The following is a description of a gene set: studied in species Homo sapiens The process whose specific outcome is the progression of the paraxial mesoderm over time, from its formation to the mature structure. The paraxial mesoderm is the mesoderm located bilaterally adjacent to the notochord and neural tube. Human Gene Set: GOBP_PARAXIAL_MESODERM_DEVELOPMENT, and this is the list of marker genes: WNT5A, FGFR1, SMAD3, SMAD2 (NCBI Gene Id 654050), WNT3A, EXOC4, WNT11, TCF15, LEF1, FOXC2 (forkhead box C2), NCKAP1, BMPR1A, POGLUT1, DLL3, TEAD2, EPB41L5, ZIC3, YAP1, NUP133, FOXC1